Given this list of marker genes AIP, CDKN2B, CDKN2C, CDKN1B, CDKN1A, GPR101, MEN1, YY1, here is a description of the gene set: Pituitary prolactin cell adenoma species: Homo sapiens A type of pituitary adenoma originating in prolactin secreting cells. This kind of adenoma is characterized by overproduction of prolactin, and may cause loss of menstrual periods and breast milk production in women. Human Gene Set: HP_PITUITARY_PROLACTIN_CELL_ADENOMA